The following is a description of a gene set: from publication Peltier DC, Simms A, Farmer JR, Miller DJ (PMID 20483728) Human Gene Set: GSE16450_CTRL_VS_IFNA_6H_STIM_MATURE_NEURON_CELL_LINE_DN Human neuronal differentiation alters responsiveness to innate immune stimuli and virus infections. We used microarrays to examine the transcriptional responses of the human BE(2)-C neuroblastoma cell line to retinoic acid-induced differentiation and type I IFN stimulation. species: Homo sapiens Genes down-regulated in mature neuron cell line: control versus interferon alpha (6h)., and this is the list of marker genes: NTN1, COX8A, EIF2S3, ADAP1, YIPF4, ALDH4A1, SAT1, HYLS1, KSR1, SLC2A3, NEDD8, TTC1, YWHAZ, ERCC2, CD53, CNPY3, CCAR2, HNRNPL, MT2A, AKT1S1, COX20, TMC4, STK11, EIF4EBP2, TMEM81 (NCBI Gene Id 388730), RRAGA, CCNI, SLC14A1, FAM241B (NCBI Gene Id 219738), MICOS13, EBI3, LMBR1L, PTGES3, GOLT1B, IL21R, FTH1, BTG2, IFNAR1, CHADL, LAMTOR4 (NCBI Gene Id 392758), TPP2, EIF4A1, TBC1D10A, RBM17 (RNA binding motif protein 17), AQP12A, PFDN2, IPCEF1, KDM3B, LARP7, SDHC, N4BP2L2, MPDU1, ADRB2, OS9, PPIE, MYH9, BCL2L15, ARID1A, CAST, STAMBP, CD7, HMGB2, DND1, PBX2, CSRP1, G3BP1, MID1IP1, RNF220, GPBP1L1, LAPTM4A, PFN1, RAB8A, DDX52, ILF2, GATAD2A, RARA, TIMM10B, ABCB8, HNRNPU, TP53, CDKN2AIP, EFTUD2, CRIP1, IRAK2, CASP9, UBR5, LARP1, TSNAX, LSM5, CCR4, ICOSLG, ATP5MG, PSMB7, CENPB, PNPLA7, WDR1, S100A10, ZFAND6, GIGYF1, ORAI2, RASSF3, ITGAL, AKAP13, SPOP, RAB4A, PATJ, SETD1B, XPA, BRD3OS, ARPC4, SAFB (scaffold attachment factor B), FGFRL1, AP3B1, IRF4, HMGCR, DYNC1LI1, EIF4B, EML4, LSM6, ASS1 (argininosuccinate synthase 1), UBE2S, TRAF4, UBE2I, PECAM1, TSHZ1, UBAC2, NPLOC4, POLR3F, ITPKB, GIMAP6, CD81, MALAT1, SLC22A5, C15orf39, HADHA, VPS54, HNRNPD, PTP4A2, PCNX3, BTF3, QRICH1, S100A6, RBM25, SEC61G, CARS1, SLC25A30, SERTAD2, UFD1, PRAF2, NARF, CIRBP, ENTR1, LRFN3, ST3GAL4, IL4R, TSPYL2, IVNS1ABP, MR1, SMN1, ERF, SIDT1, CALR, MKS1, ILKAP, DGAT2 (NCBI Gene Id 84649), CNN1 (calponin 1), ADORA2A, VPS18, CD82, PSMB2, ACTR2, RAB8B, S1PR1, LSG1, NID2, KLRG1, TSC22D3, ITGB1, CD3E, KCNA3 (NCBI Gene Id 3738), MKNK2, TCF25, MARK2, SLC29A4, C20orf96, PI4KB, CD200R1, EIF2AK1, PPP4R3A, ATP6V0C, BOK, TOX, CMTR1, RTL8C, CCDC125, TNRC6B, DCAF15, CRLF3, TMEM167B (transmembrane protein 167B), NSA2